The following is a description of a gene set: A process that results in a change in state or activity of a cell (in terms of movement, secretion, enzyme production, gene expression, etc.) as a result of a brain-derived neurotrophic factor stimulus. studied in species Homo sapiens Human Gene Set: GOBP_CELLULAR_RESPONSE_TO_BRAIN_DERIVED_NEUROTROPHIC_FACTOR_STIMULUS, and this is the list of marker genes: EEF2, MAPT, TMEM108, EEF2K, WASF1 (NCBI Gene Id 8936), EIF4A3, SH3GL2, NTRK2, GRIA1